The following is a description of a gene set: studied in species Mus musculus A process involving any mechanism for tolerance induction in T cells. Mouse Gene Set: GOBP_T_CELL_TOLERANCE_INDUCTION, and this is the list of marker genes: Ido1, Itch, Runx1, Nr5a2, Lilrb4a, Foxp3, Cblb, Lilrb4b, Cd3e, Aire, H2-M3, Icos (inducible T cell co-stimulator), Tgfbr2, Cd86, Phlpp1, Il2ra